Given this list of marker genes HIF1A, TGFB1, NOS3, LTBP3, AHSG, GREM1, ECM1 (NCBI Gene Id 1893), RFLNA, PTH, SOX9, PTK2B, RFLNB, HEY2, ENPP1, TRPM4, ROCK2 (NCBI Gene Id 9475), HEY1, SRGN, ROCK1, CCL3, STATH (NCBI Gene Id 6779), GATA1, CCR1, BCOR, FGF23, MIR208A, GAS6, ASPN, NOTCH1, here is a description of the gene set: species: Homo sapiens Human Gene Set: GOBP_NEGATIVE_REGULATION_OF_BIOMINERAL_TISSUE_DEVELOPMENT Any process that stops, prevents, or reduces the frequency, rate or extent of biomineral tissue development, the formation of hard tissues that consist mainly of inorganic compounds.